Given this list of marker genes MAPKAP1, B2M, STX5, UBR7, NBDY, VRK3, STXBP1, SNCAIP, TMCO3, RRBP1, PGS1, IQSEC2, UCKL1, RUNX1T1, HPSE, SLAMF8, ZPR1, RNF31, NUB1, CCDC90B, NCF4, SLC35F6, CLDND1, CPB1, TOR3A, TRIM7, MRPL45, M1AP, LIAS, UTP3, CFAP119, PADI1, TRAFD1, STXBP2, ZBTB2, CASP1, FAM241A, KCTD8, STAT2, STK32C, RHCG, IL17RC, GLRX, XKR8, DYNC1I2, RABEP2, BIRC6, TAPBP, TAP1, URGCP, DMAC2, GOLPH3L (NCBI Gene Id 94793), GAB2, ELMOD3, ASAH2, VPS11, ZFPL1, PTPRA, CST7, CD180, ABHD12, PRG4, EFCAB2, RASA4, MKNK2, SIPA1L1, HTR2B, NOS2, NUDT13, GLA, IL15RA, TRIT1, STOML1, PPP2R3C, DNAH2, EXOC7, CNP, NMT1, IL13RA1, C19orf12, GLIPR2, FLYWCH1, ZCCHC4, ZNF688, PTTG1, PARP8, IFT56, IL12B, CTSW, MX2, DENND2B, HELZ2, LY6E, BBS2, PER1, LRP2BP, MOV10, C5, SURF1, NMI, PAPPA2, LEMD2, AP3M2, NR1H2, VRK2, HBP1, MPP7, DAO, CDK5RAP2, RBM43, COG4, CDC34, MFAP2, RAB10, GKAP1 (NCBI Gene Id 80318), LGALS3BP, DXO, TAP2, SETDB2 (NCBI Gene Id 83852), SEPTIN4, ICA1L, KDM3A, THAP4, TTC12, ADGRV1, EXOC6, TRAF2, COPS4, DDX60 (DExD/H-box helicase 60), LY86, CDKN1A, NUDT18, ENDOD1, HMX1, CLEC4E, MOCS2, IFT22, SLC5A9, CXXC4, CLN8, GNA13, PGM1, GBP4, DNMT3A, TMEM104, REEP6, KLRD1, AFG3L2, IL12RB1 (NCBI Gene Id 3594), KNOP1, ADIPOR1, LEPROTL1, FBXL12, MED10, RAB40C, ABI3, DCAF15, PPP2R5B, TMOD1, TDRD7, CCDC17, NME7, DCTN2, KDM4B, CCND2, HERC6, TSTD2, YIPF4, PEDS1, RNF114, FOXRED1, STX8, TEN1, FOXQ1, MMP2, ZNF446, HLA-DOA, SLC44A2, ZNF18, STK40, BAIAP2 (BAR/IMD domain containing adaptor protein 2), PPIG, FBXO32, CEP95, AP2B1, PPP1R11, PSMB8, FARS2, ATG2A, MISP, SERPINB8, PARP14, GAREM1 (NCBI Gene Id 64762), DNAL1, PDE7A, EPHA1, ZUP1, TLK2, GTPBP2, LRP4, here is a description of the gene set: species: Homo sapiens from publication Felker P, Seré K, Lin Q, Becker C, Hristov M, Hieronymus T, Zenke M (PMID 20881193) Dendritic cells (DCs) in lymphoid tissue comprise conventional DCs (cDCs) and plasmacytoid DCs (pDCs) that develop from common DC progenitors (CDPs). CDPs are Flt3+c-kitintM-CSFR+ and reside in bone marrow. Here we describe a two-step culture system that recapitulates DC development from c-kithiFlt3-/lo multipotent progenitors (MPPs) into CDPs and further into cDC and pDC subsets. MPPs and CDPs are amplified in vitro with Flt3 ligand, stem cell factor, hyper-IL-6 and insulin- like growth factor-1. The four-factor cocktail readily induces self-renewal of MPPs and their progression into CDPs and has no self-renewal activity on CDPs. The amplified CDPs respond to all known DC poietins and generate all lymphoid tissue DCs in vivo and in vitro. Additionally, in vitro CDPs recapitulate the cell surface marker and gene expression profile of in vivo CDPs and possess a DC-primed transcription profile. Transforming growth factor-β1 (TGF-β1) impacts on CDPs and directs their differentiation towards cDCs. Genome-wide gene expression profiling of TGF-β1-induced genes identified transcription factors, such as interferon regulatory factor-4 (IRF-4) and RelB, that are implicated as instructive factors for cDC subset specification. TGF-β1 also induced the transcription factor inhibitor of differentiation/DNA binding 2 (Id2) that suppresses pDC development. Thus, TGF-β1 directs CDP differentiation into cDC by inducing both cDC instructive factors and pDC inhibitory factors. Human Gene Set: GSE22432_CONVENTIONAL_CDC_VS_PLASMACYTOID_PDC_DN Genes down-regulated in dendritic cells: common versus plasmacytoid.